Given this list of marker genes Il17a (NCBI Gene Id 16171), Zfp830, Sox9, Neurod1, Tlr4, Il10ra (interleukin 10 receptor, alpha), Inava, Slc22a21, Slc22a5, here is a description of the gene set: Mouse Gene Set: GOBP_INTESTINAL_EPITHELIAL_STRUCTURE_MAINTENANCE A tissue homeostatic process required for the maintenance of the structure of the intestinal epithelium. studied in species Mus musculus